Given this list of marker genes ZCCHC8, ZEB1, RGS10 (regulator of G protein signaling 10), TNIP1, BOLA2, USP12, TRAF4, NIFK, XPO6, RPP25L, LARP1, SLFN13, ORC2 (NCBI Gene Id 4999), SAFB, PSMB9, PSMB8, CAPN15, IRF9, BST2, RANBP10, PRPF6, ATG101, SFSWAP, OLFM3, USP18, FRAT2, VPS11, DCAF11, OSBP, NSUN4, ST8SIA1, PARP12, MEDAG, SART1, FKBPL, ALKBH4, DUS1L, HEATR1, TM9SF2 (NCBI Gene Id 9375), RNF145, CHMP7, RNF114, RRBP1, GBP2, UBAP1, RNPS1, GRAMD1A, NKTR, NXT1, AGRN, FAM8A1, DLGAP4, KIF1B, SSBP2, LONP1, TRIR, ARFGEF1, DHX57, UBE2Z, OAS1, DAP3, STAT1, STX5, NUFIP1, SLITRK1, IFIT1B, TLE4, PTOV1, ENC1, MAF1, TXNL4A, RAB3IP, SPRTN, ULK1, CTDP1 (NCBI Gene Id 9150), ELP5, GBP6, NGRN, HLA-G, BLTP2, RRP12, NUP43, C8orf33, TPRKB, FOXJ3, XDH, WDR43, CHKB (choline kinase beta), EIF4A3, DICER1, TRIM59, MBP, MRPL46, GMPPB, FBXO22, PSME1, SLC25A26, AHSA1, RBMX2, CTDSP2, IKBKE, HAUS8, TSTD2, RAPGEF6, GLE1, GTF2H4, PPAN, HGSNAT, POLR1A, EIF3D, TMEM140 (transmembrane protein 140), IL7R, DDX24, RNF11, VPS16, POP7, CRIM1, RBM42, PGP, CRY2, RRN3, RNF185, RELA, B9D2, PARP14 (NCBI Gene Id 54625), HBP1, PITPNM1, TDRP, NEK9, MRPS31, HLA-B, IFIT2, PATJ, ATP6V1E1, MARVELD2, DDX60, ABLIM1, PIK3C3, EIPR1, RHEBL1, RAB40C, GPN1, IFI35, ZNF790, IFIT3, SEC61G, COL9A2, NRG3, GTF3C4, AVL9, AXIN1, SOWAHA, CELSR1, HARS2, SLX9, ZNF394, UBA5, HOXA11, KCNN4, GOLGA5, IRF1, CPSF1, LGALS3BP (galectin 3 binding protein), STUB1, FKBP4, LCMT2, ZNRF1, FBXO45, PUF60, BCL2L11, ATP6V0D1, SSX2IP, MPDU1, SLC44A2, EFR3A, PPP1R8, RTP4, PDXK (NCBI Gene Id 8566), DDHD2, ZNF764, DOP1B, INPP5D, SS18, PITHD1, NDUFS6, MESD, MRPS18B, GCH1, CMPK2, PARP9, IFI27L2, DCTN6, LAS1L, MIB2, SEC11A, EPSTI1, TNFRSF18, CDK11B, METAP1D, ELAC2, here is a description of the gene set: studied in species Homo sapiens Genes down-regulated in Ly6C monocytes: high versus low. PPARγ is known for its anti-inflammatory actions in macrophages. However, which macrophage populations express PPARγ in vivo and how it regulates tissue homeostasis in the steady state and during inflammation is not completely understood. We show that lung and spleen macrophages constitutively expressed PPARγ, while other macrophage populations did not. Recruitment of monocytes to sites of inflammation was associated with induction of PPARγ as they differentiated to macrophages. Its absence in these macrophages led to failed resolution of inflammation, characterized by persistent, low-level recruitment of leukocytes. Conversely, PPARγ agonists supported an earlier cessation in leukocyte recruitment during resolution of acute inflammation and likewise suppressed monocyte recruitment to chronically inflamed atherosclerotic vessels. In the steady state, PPARγ deficiency in macrophages had no obvious impact in the spleen but profoundly altered cellular lipid homeostasis in lung macrophages. Reminiscent of pulmonary alveolar proteinosis, LysM-Cre x PPARγflox/flox mice displayed mild leukocytic inflammation in the steady-state lung and succumbed faster to mortality upon infection with S. pneumoniae. Surprisingly, this mortality was not due to overly exuberant inflammation, but instead to impaired bacterial clearance. Thus, in addition to its anti-inflammatory role in promoting resolution of inflammation, PPARγ sustains functionality in lung macrophages and thereby has a pivotal role in supporting pulmonary host defense. from publication Gautier EL, Chow A, Spanbroek R, Marcelin G, Greter M, Jakubzick C, Bogunovic M, Leboeuf M, van Rooijen N, Habenicht AJ, Merad M, Randolph GJ (PMID 22855714) Human Gene Set: GSE32034_LY6C_HIGH_VS_LOW_MONOCYTE_DN